Given this list of marker genes Rbm24, Rbpms, Hnrnpl, Hnrnpa2b1, Hnrnpk, Unk, here is a description of the gene set: Mouse Gene Set: GOMF_MRNA_CDS_BINDING species: Mus musculus Binding to an mRNA molecule coding sequence (CDS).